The following is a description of a gene set: The process that results in the return of receptor molecules to an active state and an active cellular location after they have been stimulated by a ligand. An active state is when the receptor is ready to receive a signal. studied in species Mus musculus Mouse Gene Set: GOBP_RECEPTOR_RECYCLING, and this is the list of marker genes: Ehd3, Eps15, Inpp5f (NCBI Gene Id 79372), Gria1, Optn, Ache, Psen2, Pex1, Plekhj1, Tbc1d16, Kif16b, Ramp3, Arfgef2, Vamp3, Arap1, Nsf, Ap1ar, Ide, Pex2, Pex6, Pex12, Grin2a, Snx16, Rab11b, Nsg1, Ece1, Snca, Pcsk9, Caml, Ctsd, Trat1, Usp9x, Rep15, Als2, Gria3, Bves, Ldlr, Sorl1, Chmp5, Plekha3, Ptpn2, Scrib, Lmtk2, Pex10, Pheta2, Pheta1, Rab29, Anxa2, Gria2, Ptpn1, Psen1, Dab2, Agtr1a, Pex5, Lamtor1